The following is a description of a gene set: Any process that initiates an immune response. studied in species Homo sapiens Human Gene Set: GOBP_ACTIVATION_OF_IMMUNE_RESPONSE, and this is the list of marker genes: CYBA (NCBI Gene Id 1535), FCRL3, PYDC5, MIR146A, ARRB2, FYB2, TNIP3, IRAK1, IFI35, CBLB, PPT1, LRRC14, C4BPA, CFI, PUM2, RNF170 (NCBI Gene Id 96586), C2, PIK3AP1, LCK, NOD2, UBASH3A, FYB1, OTULIN, IRF3, FPR3, APP, RGCC, FOXP3, BTNL9, IGHG2, CFD, MAPK8, TKFC, TYRO3, TIFA (TRAF interacting protein with forkhead associated domain), PUM1, BECN1, PLPP4, GATA3, RBCK1, PIK3R1, ZDHHC3, GBP2, TNFRSF21, BTN2A1, BPIFB1, IFIH1, GPLD1, RFTN1, ELF1, MIR20A, FPR2, TLR10, TICAM2, TRGC2, IRAK4, IRF5, CD226, OAS1, VTCN1, FOSL2 (FOS like 2, AP-1 transcription factor subunit), ESR1, FCN1, SCIMP, C8B, SPSB3, MASP2, BAG6, KLRD1, TBK1, LETMD1, NFAM1, SLC39A10, IGHA1, PLEKHA1, MIR200C, ZNRF1, HLA-A, NEK7, GRB2, ZNRF4, NMI, LILRB4, SCARA3, CD8B, BTN2A2, NOS2, TRAF3, LIMK1, NR1H3, ZNFX1, SLC15A2, EIF2AK2 (NCBI Gene Id 5610), TRBC2, PLA2G6, TAB1, OGT, CTSS, SOS1 (SOS Ras/Rac guanine nucleotide exchange factor 1), LSM14A, IRAK3, EIF2B2, CD274, IGLC7, PTPRC, CEACAM1, STMP1, MAP3K7 (mitogen-activated protein kinase kinase kinase 7), P2RX7, ACOD1, FCN2, APPL2, NR1H4, RC3H2, TLR5, OASL, PCBP2, NFATC2, RAP1A, BANF1, DHX33, SLA2, PQBP1, BAX (NCBI Gene Id 581), PTPN2, BCAR1, NLRP1, BTNL10P, WASHC4, CFH, RNF144A, CLU, UBQLN1, FCN3, TMIGD3, SYK, NLRP2B, RIOK3, EZR, FCER2, TLR1, COLEC10, EPG5, NFKBIL1, SLC39A6, FCER1G, C3, GCSAML, PLD2, HSPA1A, C1R, PDPK1, TLR3, GPR108, STAP1 (signal transducing adaptor family member 1), CD247, NAIP, KLRC4-KLRK1, LAT, CD47, PAK1, MIR708, CD3D, ITK, MAPKAPK2, TRIM3 (NCBI Gene Id 10612), STING1, MATR3, IGLC6, ADA, HLA-DRB1, KCNJ8, CTLA4, PTPRJ, IKBKB, GRAMD4, CASP1, EP300, SIVA1, TNIP1, MALT1, TREM2, RNF34, CRKL, LATS1, THEMIS, CFHR4, STOML2, TRIM32, PDE4B, CD276, RAB7B, MS4A1, USP50, SPG21, OAS3, CHUK, CD79A, CPTP, MASP1, GKN2, C7, VAV3, C4BPB, ZC3HAV1, MIR210, BTN3A1, CACTIN, RC3H1, KLRC1, TLR8, HMSD, USP17L2, C3AR1, HDAC6, C8A, GPR33, CD36, IRAK2, LILRA4, SFPQ, HCFC2, HRAS, NLRX1, RPS6KA3, SIN3A, FOXP1, EIF2B3, NLRP6, MFHAS1, RPS3, MIR18A, CD300LD, CD28 (CD28 molecule), PARP1, PRKCB, PHB1, LAPTM5, TRIM5 (NCBI Gene Id 85363), IGLC1, ITPRIPL1, RBM14, NOD1, APPL1, RNF125, FFAR2, C9, LATS2, LTF, CCDC134 (coiled-coil domain containing 134), LRCH4 (NCBI Gene Id 4034), TRBC1, TICAM1 (TIR domain containing adaptor molecule 1), HSP90AA1, CREBBP, PAK3, TRIM65, LRRC19, TNIP2, KCNK13, PPP6C, PLCG1, DGKZ, GFI1, CMTM3, F2RL1, VSIG4, ZDHHC9, CLEC4E, LILRA2, XIAP, RIPK2, TRAF3IP3, PVRIG, DENND1B, GDI1, ABHD8, ZDHHC5, ALPK1, PLCG2, KLRK1, MAPKAPK3, CD55, KLRC2, HAVCR2, PYCARD, HEXIM1, WNK1, THY1, TLR6, ZCCHC3, CD72, ELP6, C5AR2, MIR140, BIRC3, MBL2, C1S, FOSL1, FBXL2, BRAF, UNC93B1, GBP1, CACNB3, RIGI, YES1, CD300LB, CD22, MIR34A, IGHE, NAGK, SEC14L1, PHB2, IPO5, TEC, C1QB, CD38, PHPT1, CARD8, PRKCH, CD5L, FLOT2, MICB, CD2AP, LIME1 (NCBI Gene Id 54923), TLR4, TNFAIP3, FYN, BIRC2, CLEC7A, RNF31, EIF2B4, BRCC3, FGR, THEMIS2, USP15, CD300LF, PTPN22, NFKBIA, NPLOC4 (NPL4 homolog, ubiquitin recognition factor), KHDRBS1, NCKAP1L, SLC15A4, C8G, NFKBIZ, IGHG1, HSPD1, MARK4, MAP2K6, TRAT1, FCGR2B, TARBP2, TRIM11, OTUD4, TRGC1, CR1L, RAB29 (NCBI Gene Id 8934), IRF7, PRAM1, HLA-DQB1, PSEN1, FCMR, HLA-DRB3, CD3G, CD79B, C4A, NLRC4, ATAT1, INPP5D, CFHR1, MOG, WDFY1, IGHG4, PLSCR1, TSPAN6, TESPA1, LCP2, NAGLU, DUSP3, NFKB1, KLRC3, SLC15A3, PTK2, HSP90B1, RNF135, TREX1, DDX60, HCK, LYPLAL1, HSPA8, NFKBID, PAK2, ICOSLG, LYN, TRDC, CD8A, REG3G, KCNN4, CACNB4, CFB, SLC19A1, CFP, KIR2DS2, BTNL3, C1QA, C1QC, IGKC, TNF, NECTIN2, PDE4D, BMX, KRT1, KLRC4, MAPK1, CFHR2, RTN4, ZBP1, CFHR5, PRKDC, PIK3CD, BTN2A3P, MIR520B, IKBKG, GBP5, XRCC5, KLHL6, MNDA, DHX58, CFHR3, CD59, IL1B, CAV1, RELA, RAB11FIP2, LIPA, PYDC1, BTNL2, S100A9, STK11, ITGAM, MYO1G, TLR7, TYROBP, PJA2, NLRP3, IFNG, CLPB, GCSAM, BLNK, NONO, ZDHHC1, BCL2, ERMAP (erythroblast membrane associated protein (Scianna blood group)), RABGEF1, NLRC3, TRAF6, YWHAE, CLEC6A, DDX3X, BTN1A1, CD300A, C1QBP, NLRP10, AKT1, LAT2, PYDC2, TLR2, TAX1BP1, BTN3A2, BCL10, PRNP, BTN3A3, COLEC12, LAMP2, PRKD2, DAB2IP, LGALS9, UBE2N, HMGB1, TRAC, LPXN, SUSD4, SKAP1, MIR149, PAWR (NCBI Gene Id 5074), DUSP22, SQSTM1, ABL1, ABHD17A, ANKRD17, CD81, MEFV, SLC46A2, IRF1, PRKD1, PSPC1, MAVS, AARS2, VAV2, LGR4, IRGM, AIM2, CYLD, HHLA2, MIR200B, SHB, RSAD2, MIR17, BTNL8, CD46, SMPDL3B, TXK, MIR520E, TLR9, SH2D1A, PIK3CA, LACC1, BANK1, SERPING1, NINJ1, LGALS3, LAX1, CD14, TIRAP, ZAP70, TRIM31, FCHO1, HLA-DPB1 (NCBI Gene Id 3115), PTPRS, SPPL3, ZNF683, CD160, AP3B1, RNF115, S100A8, TRIM15, KCNK6, CR1, AURKB (NCBI Gene Id 9212), ZC3H12A, ITCH, MARCHF5, IGHD, LY96, IFI16, C5AR1, NOP53, PRKCE, PTPN6, FLOT1, HSPA1B, C1RL, NR4A3, XRCC6 (NCBI Gene Id 94359), MYD88, CCR7, MIR19A, GPATCH3, TASL, VAV1, NR1D1, MIR4691, PELI1, EIF2B5, SMPDL3A (NCBI Gene Id 10924), ZDHHC18, GPR32P1, FPR1, PPP2CA, SH2B2, C6, S100A14, IGHA2, CD19, ZDHHC12, COLEC11, A2M, NCR3, SRC, CSNK1A1, PYHIN1, CARD11, TIFAB, TOMM70, UFD1, ERBIN, IGLC3, TRIL, NCK1, PRKCD, SIRT2, CSK, GPS2, IGHM, IRF4, RNF39 (NCBI Gene Id 80352), BTRC, TMEM126A, TREML4, IGHG3, BTK, C5, TRIM25, SARM1, BLK, DDX41, ECSIT, C4B, GPR32 (NCBI Gene Id 2854), CASP6, MEF2C, UBR2, PLCL2, CMKLR1, INAVA, IKBKE, CGAS, CD3E, CR2, LBP, EIF2B1